The following is a description of a gene set: species: Mus musculus Mouse Gene Set: GOBP_CHRONIC_INFLAMMATORY_RESPONSE_TO_ANTIGENIC_STIMULUS A chronic inflammatory response to an antigenic stimulus. A chronic inflammatory response persists indefinitely during days, weeks, or months in the life of an individual., and this is the list of marker genes: Tnf, Ahcyl, Trav7-2, Il10, Lta, Ahcy